The following is a description of a gene set: Human cytomegalovirus induces a pro-inflammatory monocyte following infection and we have evidence that NF-κB and phosphatidylinositol 3-kinase are key mediators in this early activation. To begin to address how these signalling pathways are responsible for the rapid activation of infected monocytes, we examined the role these pathways played in the transcriptome of infected monocytes. Global transcriptional profiling using cDNA microarrays revealed a significant number of genes, including inflammatory genes, were regulated in a NF-κB- and/or PI(3)K-dependent manner, identifying these pathways as key cellular control points in the conversion of monocytes to an activated pro-inflammatory state following HCMV infection. from publication Chan G, Bivins-Smith ER, Smith MS, Yurochko AD (PMID 18003728) Genes down-regulated in monocytes after HCMV infection: untreated versus Ly294002. Human Gene Set: GSE9601_UNTREATED_VS_PI3K_INHIBITOR_TREATED_HCMV_INF_MONOCYTE_DN studied in species Homo sapiens, and this is the list of marker genes: ASAP1, SIAE, TRDMT1, LETM2, MRPL39 (mitochondrial ribosomal protein L39), TSPAN5 (tetraspanin 5), ACTL9, METTL2B, AP4E1, PLAAT1, ELOVL6, SLC49A4, NXNL2, ADHFE1, PKP2, P2RY14, ZDHHC22, PTPN13, CCDC138, S1PR5, SLC16A1, VEZF1 (NCBI Gene Id 7716), CRISPLD2, LRRK2, MFHAS1, ITGB5, NDRG2, EBF2, MRPL50, ERCC5, SLC47A2, PDZK1IP1, ACP3, CFL2, ENOX2, TAL2 (NCBI Gene Id 6887), TNPO3, MORF4L1, SCP2, SMPD2, RNF111, DGAT1, TMEM17, OSGIN2, LAMA3, SCARNA13, HACL1, TM2D1, TRIM13, CLPTM1L, LYRM4, PRCP, ABRAXAS1, BBS2, IRAK3, PTPRK (protein tyrosine phosphatase receptor type K), ZDHHC15, SEPTIN8, LDAF1, SELENOI, THEMIS, USP33, SEC16A, CSPP1, KCNRG, LIX1L, CSNK1G1 (casein kinase 1 gamma 1), ARL6IP6, KLF7, TNFRSF8, PABPC1, ARMCX2, PGAP3, SYP, ZMYM5, BRAF, CYB561, IDUA, MEP1B, TMEM50B, GPR89B (NCBI Gene Id 728932), INSIG2, PHEX, PRKRA (NCBI Gene Id 94716), ZXDC, NANOG, DPAGT1, LCOR, MIR670, CD72, PLAA, DCTN5, KCTD6, GRB14, POLR2H, DCUN1D1, C3orf52, TMEM81, RDH16, ADGRB1, PJA2, RTP3, LEF1, PKHD1L1, CDKL3, EXOC6B, DUSP28, NCOA3, CPSF2, MT-ND2, KRTAP13-1, ERLEC1, DRAM2, RAB31, TRIM37, PURB, GPAM, APOL6, CKLF, METTL8, ITGA2, DCAF12, AIG1, LPAR6, TNFRSF11B, POLR3K, PKN2, DYNLL1, SHROOM2, TCF7, GPR55, NARF, SEC61A2, CPM, C2orf49, LIPA, MKS1, EIF2B3, RSU1, MFGE8, FASTKD3, SLC35B1, ITGAD, HLCS, ABCD3, CCR7, DOLPP1, LTBR, CMA1, CDC37L1